The following is a description of a gene set: Genes containing one or more binding sites for (Gsk3b) in their promoter regions (TSS -1000,+100 bp) as identified by GTRD version 20.06 ChIP-seq harmonization. from publication Yevshin I, Sharipov R, Kolmykov S, Kondrakhin Y, Kolpakov F (PMID 30445619) Mouse Gene Set: GSK3B_TARGET_GENES species: Mus musculus, and this is the list of marker genes: Timm10b, Spag5, Dpy30, Gm13226 (predicted gene 13226), Ptp4a1, D17H6S53E, Dbn1, Cdk11b, Gdap2, Cops3, Mir8105, Zkscan14, Map3k5, Gm9415, Slc2a1, Pole, Miip, Wbp2, Sars2, Tug1, Cabin1, Wdr38, Gm14963, S100a4, mt-Tt, Ing1, Rps6ka1, Gm12315, Ermp1, Nckap5l, Qser1, Zfp469 (zinc finger protein 469), Gtpbp2, Zdhhc17, Ormdl1, Pcbp4, Cd300ld, Hps6, Hsd11b2, Dnajc28, Ptrh2, Naxd, Brd7, Nup35, Tnfrsf19, Mrpl48, Snx11, Tardbp, Fam204a, Usp38, Odr4, Dlg1, Tnxa, Gmfb, Ttll5, Tjp2, Gm26224, Smarca5, Nos1 (nitric oxide synthase 1, neuronal), Lgals12, St7l, Pamr1, Nherf1, Ier2, Zc3h6, Bnip3, Ecpas, S100pbp, Rian, Pias3, Ppm1l, Il18bp, 4933417G07Rik, Gm24233, Decr1, Lonp1, Galnt1, Agpat4, Ppp1r13l, Hyal3, Ube2l6, Itpka, Rbbp8, Phf19, Prmt2, Rny1, Adora2b, Slc9a1, Cep89, Rexo1, Bzw1, Ppp4r3b, Bet1l, Gm23100, Prmt9, Hsph1, Gm23661, Ccnt1, Fbxo33, Pcbp3, Meox2, Atosa, Acat3, Lgalsl, Zswim7 (NCBI Gene Id 69747), Calm1, Rnu11, Gm10644, Rara, Sephs1, Dnhd1, Smad3, Bcl11b, Prr3, Atp6v0d1, Ocel1, 9330154J02Rik, Extl3, Srrm4 (serine/arginine repetitive matrix 4), Arap1, Slc11a1, Klc2, Zfp821, Ap3d1, Frmd8, Tnfrsf26, A530013C23Rik, 4930503O07Rik, Ctnnb1, Galnt6, Rac1, Pvt1, Rcor1, Armc8, Usp21, Smim8, Kat6a, Phlpp1, Ndufaf2, Piezo1, Zfp407, Gm14285, Gm11381, Gm24723, Armt1, Grm6, Krtap1-4, Snrpa, Cyfip2, Fam193a, Poll, Arf2, Gm20522 (predicted gene 20522), Coq10b, Cops7b, Slc19a1, Diaph1, Mir7036b, Gk, Ica1, Speg, Slit3, Gm10067, Gm13562, Atxn2l, Actmap, Crbn, Tut4, Chaserr, Slc4a1, Gm24326, Katnbl1, Psmb8, Uba52, Hras, Incenp, Gm40190, Pcdhga11, Klhdc8a, Amotl2, Synpo, Smarca2, Asb15, Cd2bp2, Noct, Hoxa1, Gm10143, Maea, Tmem79, 4921524J17Rik, Cibar2, Ppip5k2, Acap3 (ArfGAP with coiled-coil, ankyrin repeat and PH domains 3), Nts, Ggnbp1, Coro1b, Slc25a10, Micall2, Chmp3, Thap4, Epha2, Pard3, Mpi, Zfand3, Gm7461 (NCBI Gene Id 674383), Psip1, Layn, Rskr, Fgf2, Cdh18, Tsg101, Kmt5a, Trappc4, Mir320, Zbtb49, Flnc, Sar1b, Gm13066, Galnt11 (polypeptide N-acetylgalactosaminyltransferase 11), Wwc2, Ube2e2, Rab34, Nek4 (NIMA (never in mitosis gene a)-related expressed kinase 4), Fchsd2, Snx21, A930001C03Rik, Cdip1, Ankrd50, Gcnt1, Apol8, Mir6935, Gm25502, Usp1, Ubr2, Nfrkb, Kti12, Ubtf, Gm23467, Slc35b1, Robo4, Foxm1, Dhrs13 (dehydrogenase/reductase 13), Gtf2ird1, Eif1ad, Ankrd2, Pms2, Iba57, n-R5s2, Gpr19, Zfp428, 1700056E22Rik, 1700082M22Rik, Lman1, Setd7, Ypel2, Thap3, Irx3os, Mir9-2hg, Zdhhc16, Tpgs1, Nvl, Tacc3, Kntc1, Gm16283, 4933440J02Rik, Cacnb3, Pabir1, Pcsk4, Slc49a4, Ptp4a3, Comtd1, Cdc42ep2, Sgk1, Zbtb6, Usp48, Pcnx3, Gm20305, Cdh11, 2310040G07Rik, Cox19, Egln1, Atp2b1, Atp11a, Kdelr1, Mier1, Atp6v0c, Man2b1, Slc46a1, Peds1, BC005624, Use1, Rnf14, Chmp2b, Cdc16, Hycc2 (hyccin PI4KA lipid kinase complex subunit 2), Crls1, Fkbp8, Mrpl50, Spc24, Atf7, Eif4ebp2, 5730596B20Rik, Pprc1, Brca1, Dhfr, Ahdc1, Rab18, 6030443J06Rik, Cyth3, Nexn, Mex3a, Arsj, Zfp383, Atp5mc3, Ercc8, Arhgap27, Fah, Zfp961, Amotl1, Lypla2, Ankrd13d (ankyrin repeat domain 13 family, member D), Adi1, Acox1, Btnl9, Ptx3, Vmp1, C030037D09Rik, Osbpl1a, Sorcs1, Nek6, Trp53bp1, A430093F15Rik, Cxxc1, Ppp6r3, Mgarp, Mgat2, Ctdspl, Gm4596, Cdk17, Podnl1, Ipo13, Ttc22, Dkk1, Tpt1, Erc1, Trim41, Cbln3, Pola2, Brd2, Sycp3, Wdr5, Cep95, Kmt2a, Sat2, Cacna1a, Vps13a, Gas5 (NCBI Gene Id 14455), Zfp511, Fam228b, Eef1a1, Lamtor4, Gm26596, Crebrf, Slc6a8, Gm37450, Tmem242, Slit2, Myh14, Kif5b, Phf1, Rpl31-ps4, Stn1, Gm35439, Fbxw2, Rabggtb, Spaca4, Gapdh (glyceraldehyde-3-phosphate dehydrogenase), Iffo1 (NCBI Gene Id 70822), Phkb, Mlxipl, Bud23, Prkci, Gm5670, Wdr4, Duxf1, Gm13594, Ift56, Gm12901, Gtf3c2, Gm15122, Arl6ip5, Mtpap, Arih2, Skic8, Pnkp, Resf1, Scarna17, Cbx2, Mir7020, Dcp1b, Rps19, Sertad1, Slc29a1, Sox5, Med26, Macf1, Icam5, Mroh2a, Cdkl2, Cfap68, Tusc1, Ces1e, Hmgn1, H3c13, Tln1, Fdxacb1, Gm9967, Mir1291, Ccdc138, Kcnk18, Pde8b, Prpsap1, Gfod2, Ik, Gm10785, Son, Casp8, Zbtb45, Mki67, Csgalnact2, Slco2b1, Erbin (NCBI Gene Id 72261), Lyar, Cacna1e, Upb1, Caap1, Trerf1, Prr11, Stag1, AA474408, Myh11, mt-Te (mitochondrially encoded tRNA glutamic acid), Rps25 (ribosomal protein S25), Ints13, Gm7299, Odad4, Ttll1, Hid1, Gm26205, Atg5lrt, Sec16a, Acbd4, Cebpzos, Aim2, Gnat1, Prpf19, Socs2, Cpeb1, Kif21b, Tmem101, Gm53, Dpysl3, Col1a1, Mir6236, Atp13a1, Ttc7, Capza1, Marchf7, Pum3, Nlgn2, Gm10819, Sgms1os1 (Sgms1 opposite strand transcript 1), Eed (NCBI Gene Id 16759), Galk2, Ap2s1, Bbs12, Rita1, Smc6, Myc (NCBI Gene Id 17869), Cbarp, Alas1, Pgap2, Ctnnal1, Thra, Rnf44, 4933427D14Rik, Pja1, Blcap, Gm14197, Ube2s, Pin4, Tgfb1, Mir100hg, Snx4, Qars1, Capns1, Ttc13, Dync1h1, Limd2, Hdac2, Ssc5d, Bbs7, Fbxw7, Prr19, Ndufc1, Plch2, Yars1, Polr2i (polymerase (RNA) II (DNA directed) polypeptide I), Ear6, Ptprz1, Cldn23, Nt5dc1, Hif1a, Rabl2, Gm15418, Klc1, Triobp, Gnl1, Stxbp2, Dcaf12, Gng12 (NCBI Gene Id 72111), Ccdc78, Col7a1, Rtp3, Nup133, Rmdn3, Ttll13, Wasf1, Ptov1, Gm25422, Eldr, Zfp599, Atp5mc2, Pan2, Ceacam3, Kxd1, Magi2, Fbxw4, Pfn1, Vps36 (vacuolar protein sorting 36), Pcdh1, Prl5a1 (NCBI Gene Id 74232), Samhd1, Mir7668, 3425401B19Rik, Cx3cl1, Macir (NCBI Gene Id 98651), Psmc1, 4930453N24Rik, Usp35, Psph, Gm6680, Mrpl45, Rad1, Zbtb9, Gm12363, Sgms1, Atp6v1b2, Taf1a, Tafazzin, 4930597O21Rik, Nob1, Capg, Mir145a, Ypel3 (yippee like 3), Vrtn, Spata6l, Trpv6, Trmt10c, Slc12a1, Serpinb8, Ash2l, Fam118a, Selenoi, Aste1, Ablim1, Map2k5, Vps35, Hspg2, Slc30a1, Hspbap1, Tas2r144, Ccny, Kmt2d, Dtwd2, Pnrc1, Chil3, Nsl1, Gm28535, Zbtb1, Dpcd, Vps13d, Gtf2h3, Sacm1l, Gm11725, Jade1, Tas2r135, Ddit3, Gm16118, Gm15564, Myl12b, Kctd9, Txn2, Commd3, Gm4285, Gm5046, 1700030C14Rik, Riiad1, Csnk1g2, Ndufv1, Col1a2, Arfip2, Slc23a1, 2810442N19Rik, B230216N24Rik, Ugdh, Wipi2, Baz1b, Cars2, Pds5b, Sfxn5 (NCBI Gene Id 94282), Mcf2l, Tsc2 (NCBI Gene Id 22084), Tmcc3 (NCBI Gene Id 97668), 4930513N10Rik, Gm20091, Trmt44, Igf2r, Cenpt, Gpn3, Col11a1, Prkn, 4931406C07Rik, Fam168b, Dohh, Tm7sf2, Mpdu1, Spcs2, Bhlhe41, Smarcc2, A930041C12Rik, Trim62, Elmod3, A430078I02Rik, Cyp3a63-ps, Gm8837, Vps8, Arhgef10, Meak7, Rpp21, Cacna1c, Acly, Suco, Ddx19a, Rdh16, Golga7, Znrd2, Chmp2a, Acad12, Pde4c, Rp31-ps19 (NCBI Gene Id 100039275), Zmiz1, Aip, Smarcad1, Pithd1, Cdk2, Lingo1 (leucine rich repeat and Ig domain containing 1), Tgm2, Olfml3, Aldoa, Rpl7a-ps8, Wdr6, Gm19265, Gtf2b, Asf1b, Ppp4r1l-ps, Ddx5, mt-Rnr2, Sestd1, Pms1, Pou2f3, Prkaca, Dph2, Pxmp2, Emilin1, Gm14010, Naa35, Dnlz, Glg1, Zfp41, Gpi1, Txnip, Pogk, Brat1, Anapc4, Abtb3, Msh3, Azin1, Gm11228 (NCBI Gene Id 102634783, predicted gene 11228), Uqcc2, Selenop, Gm30238, Rogdi, Slc4a1ap, Abhd12, Dennd10, Mir5627, Sprtn, Eid2, Snhg17, Cpeb3, Tgif1, Ptpn23, Rap2a, Atg13, Gm25169, Bub1, Washc4, Dpy19l4, Eny2, Polr1e, Tfip11, Cyp17a1, Vps72, Ccnd1, Aars1, Garin1a, Ptpn1, Gm49405, Mettl17, St3gal3, Dlg4, Kirrel1, Pkn3, Snora68, Etv1, Gm21542, Gm17249, Trp53inp1, Hnrnpf, Scoc, Zc3h7b, Pex1, Rcan3, Cfap53, Mapk9, Mrps12, Wee2, Ppp1r9a, Tlcd1, Rpl13-ps6, Pmel, Gm30270, P4ha2, Calr, D030056L22Rik, Mllt3, Cdc40, Man1a2, Tmem63b, Ints8, Psmb4, Septin8, Gm2788, 3110070M22Rik, Arl2bp, Crispld2, Ubap1, Gli3, Morc2a, Rrp7a (NCBI Gene Id 74778), Dnajb2, Hsp90ab1, 1700001J04Rik, Rnps1, Arl6, Rfx5, Wdr75, Ccdc136, Ints1, Kcnn2, Rassf1, Gcsh, Ndc80, Klf4, Snapc2, Nt5c2, Rab11a, Gm10222, Eno4, Os9, 2900069G24Rik, Frmd4a, Eomes, Rdh5, Ccng1, Efna3 (NCBI Gene Id 99908), Gm13974, Ascc3, Donson, Ube2e3, U2af1, Gm650, Dmxl1, Gm10827, Sys1, Slfn5, Pabpc1, Mir6361, Psap, Usp16, Dock8, mt-Nd6, Kif13a, Ap4b1, Atp5f1d, Hhat, 4930444E06Rik, Axl, Rps7, Traj15, Gstz1, Egfem1, Lyst, Fbxo32, Acd, Nutf2, Tmigd3, Lsm6, Btbd2, Polr3d, Ngdn, Rubcn, 5730420D15Rik, Ddit4, Spcs1, Smg5, Htt, Xrra1, Slc45a3, Nup93, Rab3b, Cspp1, Rock2, Egfl7, Sod1, Nepro, Lrrc73, Igf1, R3hcc1l, 2810029C07Rik, Kat6b, Map3k3, Zfp335os, Pi4k2a, B3glct, Kidins220, Gm11452, Irak2, C2cd4c, Mir1231, Cetn4, Sgce, Mbd5, Agpat3, Ccnl1, Mir148a, Ybx2, Spmap1, 6430548M08Rik, Ric8a, Msrb1, Tspyl1, Zfp11, Sowahc (NCBI Gene Id 70860), Tyw5, Trmt1, Calm2, Gm17815, Ehd1, D330041H03Rik, Gm5982, Exph5, Greb1l, 4930520M14Rik, Tap1, Trim59, Rundc1, Zbtb4, C8a, Nbr1, Rab11bos1, Setd6, Gm22357, Msi2, Kdm2a, Gm4890, Sirt6, Nudcd1, Igkv20-101-2, Sec24a, Zfp606 (zinc finger protein 606), Dram1, Rnf150, Atpsckmt, Gm14488, Gm10941, Mbd6, 0610009L18Rik, Rhd, Pold2, Retsat (NCBI Gene Id 97303), Pkd2l1, Cimap2, Xrcc6, Zfp644, Wdfy3 (WD repeat and FYVE domain containing 3), Tepsin, Fam149a, 1500015L24Rik, Pank1, Trim2, Plaa, Spem2, Ltbp4, Dlg5, Cnot7, Arhgap42, 4932416K20Rik, Pigbos1, Mst1r, Stat3, Cttnbp2, Trf, Pkd2, Snord45c, Cpe, Selenow, Ift46, Cry1, Gm12689, Ccdc9, Mir3082, Ppp2cb, Ccdc191, mt-Tl1, Bcl10, Apoh, Syt7 (NCBI Gene Id 78663), Mtif2, Tbx3, Ndufa2, Dusp10, Stau2, Col5a1, Tesc, Fam241b, Gm14964, Prrt4, Nectin2, Stk4, Ndufs7, Gm15441, Tsen54, Zfp385b, Gm13669, Atg12, Mrps24, Gm23839, Myo19, Nr5a1, Por, Arl8a, Pard6a, Acaa2, Gm28651, Mcm3ap, Orc4, Pgghg, Anxa3, Tnik, Bptf, Adamts8, Senp2, Eif2ak3, Map7d1, Nradd, Klhdc4, Cnih4, Eif4h, Ankrd44, A530072M11Rik, Cpa6, Prpf3, Zc3h7a, Etl4, Anxa5, Acads, Zc2hc1b, Ptges3l (prostaglandin E synthase 3 like), Ifng, Cmklr1, Spata24, Pip5k1bos, Ptdss1, Eif4enif1, Haghl, Etv4, Atg4b, 0610009E02Rik, Recql5, 1700011L22Rik, Kif26b, Anks1, Pax6, Steap3, Ubr7, 4930500F10Rik, Hoxb5, Specc1, Gm27252, Egr1, Mvd, Usp34, Zfand1, Nectin3, Pigf, 1700030K09Rik, Ankfy1, Bid, Gart, Hes3, Gm16168, Arhgef2, Nfs1, C1qbp, Cep120, Smad7, Usp28, Kctd10, Atxn2, Mterf3, Zhx3, Mir7660, Ube2o, Zbtb14, A430005L14Rik, Mmaa, Slc9a8 (NCBI Gene Id 98868), Dzip3, Zfp36l2, Plaat3, Gm20658, Zfp788, Ubn2, Atad1, Tsn, Rere, Slc5a6, Slc35b2, Dmpk, Tektip1, Zfp639, Niban2, Mrpl38, Farp1, Mir3092, Mfsd4b1, E2f8, Hsd17b14, Pak3, Fkbp14, Satb2, Rptor, Fam133b, Bmp1, Gm12925, Lrrc42, Exoc2, Tsc22d1, Kiss1r, Add1, Gm15473, Pla2g2f, Emp1, Cdkn2c, Lix1l, Ddx59, Plekhh3, Ap2m1, Sem1, Phykpl (5-phosphohydroxy-L-lysine phospholyase), Gm15495, Cct5, 4933428P19Rik, Fam83d, Alx1, Cpsf1, Mir7653, Slc35a1, Psmd1, Nup98, Sacs, Ankrd26, Nmbr, Gm26072, Eif2ak4, Myo6, 4833412C05Rik, Btbd3, Rpl36al, Pacrg, Tdrp, Shisa6, Eif3b, Pacc1, Itpr3, Cast, Setd5, Dnajb4, Nat10, Gm7308, Senp8, Orai2, Cog2, Aktip, Nav1, Tspan5, Cald1 (caldesmon 1), Tfrc, C4a, Tmem97, Sipa1l1, Zfp974, Ccdc96, Lrrfip1, Fkbp4, Ighd6-1, Exoc3, Polr3b, Fam43a, Siah1b, Akr7a5, Cchcr1, Zbtb18, Brd3, Ppil4, Fbxo48, Gm20753, Gpam, Unc5cl, Zer1, Dlgap2, Slc26a11, Dus2, Slc25a40, 1700021P04Rik, Snx14, Opcml, Rfx1, Eef2, Lyrm2, Zng1, Zbtb37, Kdelr3, Sac3d1, Prop1, Col17a1, Utp6, Mtrr, Yipf4, Akap7, Serf1, Ufsp1, Ppp2r3a, Scarna2, Gm23119, Rsrc2, Klhdc1, Atp6v0e2, 4930555M17Rik, Maip1, Plec, Zfp143, Stoml1, Abl1, Ldb1, Sh2d6, Crtc2, Palm, Pde4d, Romo1, 1810055G02Rik, Efhc1, Psme3, Rpl6, Tesmin, 1700122E12Rik, Seh1l, Chmp6, Arhgef18, Ccdc33, Mrpl11, B3gntl1, Fzr1, Amn1, Pik3ap1, Gm4473, Trp53tg5, Vps33b, Dnase1l1 (deoxyribonuclease 1-like 1), Snora43, Sdhaf2, Phlda1, Gm10840, Dusp5 (NCBI Gene Id 240672), Trpv2, Mrpl41, Foxp2, Entrep1, Cops2, 6430550D23Rik, Raf1, Nr3c1, Agtpbp1, Arhgef17, Mbip, Prkd2, Gm24337, Acap2, Trim47, Bpifa6, Mir99ahg (NCBI Gene Id 77994), Slc66a1, Ccdc28a, S1pr2, BC048644, Adgra2, Ginm1, Spindoc, Plekha1, Tubgcp6 (tubulin, gamma complex component 6), Bap1, Herc2, 1700125G22Rik, Ttc9, Phaf1, Dvl1, Atad3a, Crebzf, Ncoa2, Gm25138, Fxyd3, mt-Tv (NCBI Gene Id 17745), Mtmr10, Usp20, Fastkd3, Hadhb, Srsf3, Gm24494, Atl2, Jak3 (NCBI Gene Id 16453), A830052D11Rik, Gm20940, Rpia, Gm22489, Lsm12, Mir219a-1, Tnk1, Bhlhe40, Gm25857 (NCBI Gene Id 115486135), Stat6, Padi4, Ctsa, Lce1e, Mid1, Zfp866, Rbm3, Gm29346, Gtf2a1 (NCBI Gene Id 83602), Fads3, Pfn4, mt-Nd1, Gtpbp4, Rhbdd1, Zfp597, Cd151 (NCBI Gene Id 12476), Actg1, Ankrd11, Sympk, Slco1a5, Gnat3, Fgfr1, Kcnab1, Trafd1, Atp5if1, Lmln, Mir7002, Dand5, Tnrc18, Ganab, Spmip8, Coro6, Atf6b, Foxa3, H2bc15, Uba6, Kifc3, Pcdh15, Cebpa, Sec61a1, Mier2, Higd1c, Pepd (peptidase D), Cdc37l1 (NCBI Gene Id 67072), Srsf9, Brix1, Dock4, Socs4, Tcirg1, Mesd, Slc39a14, Rhbdl1, Mllt6, Ctbp2, Ufc1, Gm13620, Neil3, Scn4a, Iqcc, AI839979, Polr3g, Nt5m, Rbm48, Cavin1, Lrrc56, Tmem109, Rbbp6, Cdh8, 4921504A21Rik, Rpl24, Tm9sf1, Gnao1, Gchfr, Morf4l1, Cav1, Hapstr1, Dbf4, Orc5, Gm8185, Scyl2 (SCY1-like 2 (S. cerevisiae)), Gm6556, Or5ac22, Banf1 (NCBI Gene Id 98145), Myh8, Slc25a24, Rbm3os, Rmnd1, Sh3bgrl3, Dynlt1b, Gm5766, Cdk9, Kmt5b, Naa60, Tatdn3, Aipl1, Traj61, Snrpd3, Hdac7, Wnt5a, Emx1, Nsd2, BB014433, 1700052H01Rik, Slc5a5, Kansl1, Arid5a, Tspan12, Nthl1, Vars1, Psat1, Zfp740, Tmod2, Zfp384, Trpm8, Dgcr6, Tmem134, Acvrl1, B130055M24Rik (NCBI Gene Id 654803), Myh9, Gm6368, Pacsin2, Txndc5, Dclre1b, Erlin1, Ergic3, Hddc3, Exosc1, Jagn1, Zbtb25, Gm10069, Mocs3, Gm19391, Setx, Gm38250